The following is a description of a gene set: Reactome Pathway: RHO GTPases Activate Rhotekin and Rhophilins species: Mus musculus This event has been computationally inferred from an event that has been demonstrated in another species.<p>The inference is based on the homology mapping from PANTHER. Briefly, reactions for which all involved PhysicalEntities (in input, output and catalyst) have a mapped orthologue/paralogue (for complexes at least 75% of components must have a mapping) are inferred to the other species. part of: RHO GTPase Effectors electronically inferred by orthology from the curated human pathway, and this is the list of marker genes: Rtkn, Rhpn1, Lin7b